The following is a description of a gene set: Increased concentration of methylmalonic acid in the blood. Methylmalonic acidemia species: Homo sapiens Human Gene Set: HP_METHYLMALONIC_ACIDEMIA, and this is the list of marker genes: ACSF3, MMAB, PRDX1, MTRR, MMAA, MMACHC, HCFC1, ABCD4, MMUT, SUCLG1, MMADHC, SUCLA2, ALDH6A1 (aldehyde dehydrogenase 6 family member A1), CD320, LMBRD1